Given this list of marker genes SLC32A1, ST3GAL3, MAST3, PHGDH, CDKL5, AP2M1, MAPK10, SYNGAP1, RPS6KA3, PTEN, PNKP, STXBP1, HCN2, MTHFS, GNB1, HCN1, DYRK1A (NCBI Gene Id 1859), IQSEC2, ACBD6, KCNB1, CSNK2A1, HNRNPU, PRMT7 (protein arginine methyltransferase 7), CTNNA2, ALG13 (ALG13 UDP-N-acetylglucosaminyltransferase subunit), CACNA1A, DPM1, GNAO1, PIK3CA, SLC2A1, GAMT, GNB2 (G protein subunit beta 2), NEXMIF, PIGQ, GRIN1, GABRD, CASK, ARX, ALDH7A1, CHD2, SCN9A, CRELD1, DOHH, PRRT2, SLC25A22, SCN1A, GRM7, CNTNAP2, PLPBP, PIGP, KCNA1, SPTAN1, EPM2A, GOSR2, PAFAH1B1, SCN2A, PIGM, GPAA1, DNM1 (NCBI Gene Id 1759), ARFGEF1, GRIN2A, ADGRV1, STX1B, KCNC2, POLR1A, ALDH4A1, GABRA1, FZR1, NHLRC1, ASAH1, ADGRG1, ATP6AP2, RUSC2, SIK1, TRIM8, SCN1B, FRRS1L, FGF13, GABRG2, GRIK2, DOCK7, ATP6V0C, GABRB3, CUX2, MTOR, SLC6A1, NGLY1, COX8A, PCDH19 (protocadherin 19), NEUROD2, PRICKLE1, CAMK2B (NCBI Gene Id 816), EHMT1, DMXL2 (NCBI Gene Id 23312), CEP85L, AKT3, here is a description of the gene set: Human Gene Set: HP_ATONIC_SEIZURE studied in species Homo sapiens Atonic seizure is a type of motor seizure characterized by a sudden loss or diminution of muscle tone without apparent preceding myoclonic or tonic event lasting about 1 to 2 seconds, involving head, trunk, jaw, or limb musculature. Atonic seizure